Given this list of marker genes SLC6A4, GABRE, ERBB4, GRIN1, ELFN1, IGSF21, RAPSN, GRM1 (glutamate metabotropic receptor 1), ELFN2, LPAR1, CACNG2, GRID2IP, GPHN, DNAJA3, CHRNA6, NEO1, PRRT2, ATP2B2, ABHD6, STX1A, GRIK4, GRM7 (NCBI Gene Id 2917), EPHB2, LRFN1, ATP6AP2, CHRM3, GRIK2, CHRNA4, DLG3, KCTD12, TMUB1, CNIH2, GABRB3, SLC6A3, SSPN, MAGEE1, TMEM108, LRRC7, CHRM1, RYK, DAGLA, GABRG3, FARP1, P2RX1, GPR158, HTR3E, GRIA3, GRIN2D, KCNC4, LRRTM1, GRIN2C, GABRA1, ADORA2A, CHRNG, P2RY1, SIGMAR1, NLGN4X (NCBI Gene Id 64642), CHRNA10, CHRNA3, CACNG7, NLGN3, ACTN2, HCN1, HTR3C, LRRC4, MUSK, SHANK2, CLSTN2, CHRNA7, ADRA2A, ITGA8 (NCBI Gene Id 8516), LRFN2, FGF22, GABRA2, SORCS3, ANK3, CHRNB4, SEMA4C, CBLN1, HTR3D, ANP32E, CTNNB1, SLITRK1, GRIK3, CLMP, KCNJ4, KCNH1, GABRR2, ADAM22, TMEM240, LRFN4, SLC6A6, CNKSR2, LRRTM4, CLSTN1, GABRR3, CTNNA2, LRRTM2, GABRB1, CHRNB1, CACNG3, PCDH8, ADCY1, GRID1, LRRC4C, NLGN2, ASIC2, KCNMA1, GRIK5, ITGA3, SYAP1, SYNE1, MKLN1, SHISA9, TRPV1, FBXO2, HTR3A, C1QA, CACNA1C, EPHA7 (EPH receptor A7), PTPRO, GRIK1, CNTN2, SUSD4, DDN, ABHD17A, LRRC4B, CSMD2, RNF10, SYNDIG1, OPRK1, ATAD1, NETO1, FBXO45, KCTD16, FLRT3, NECTIN3, NAPEPLD, DCC, SRGAP2, CRKL (NCBI Gene Id 1399), GLRA3, VWC2, RPH3A, CNIH3, NLGN4Y, EFNB2, DLG4, CHRM2, GLRB (NCBI Gene Id 2743), IGSF9, GABBR2, LRRTM3, EPHA4 (NCBI Gene Id 401031), CACNG8, GRM5, GABRG2, ABHD17B, NSG2, LHFPL4, CLSTN3, TENM2, F2R, CHRNE, ADORA1, IQSEC3, PCDH10, PTPRS, CHRNB3, DMD, CHRNA9, IL1RAPL1, CHRM4, GRIA1, GRM3, AKAP9, CHRNA5, PDLIM4, SLITRK2, ANK1, DLG1, LIN7B, FLRT2, SHANK1, LRP8, KCNJ2, SYT1 (synaptotagmin 1), PTCH1, GABRR1, GABRA3, HTR5A, SHANK3, DLG2, GABRA5, PRR7, GABRB2, KCNC2, GPR179, GNB5, PICALM, GNAO1, SHISA6, FMR1, KCNC1, ANK2, ADGRL2, SHC4, DNM2, CNTN1, NRGN, LIN7A, NLGN1, SLITRK5, RAC1, GLRA1, KCNB1, ITGA5, KCNK2, NRP2, GRIA2, PCDH17, SLC16A7, PLXNB1, CRHR1, CHRM5, CNR2, NRP1, GRIN3B, VANGL2, GRIN3A, SEMA4B, COL13A1, ITGB3, KCNA2, GABRG1, DRD2, GRM2, DOK7, SEMA4F, SHISA7, CHRNA2, OPRD1, SHISA8, P2RX6, ADGRB3, GABRA4, SLITRK3, FXYD6, GABBR1, GRIN2A, NRCAM, AKAP5, GRID2, LRFN3, STRN, PLPPR4, CADPS2, DBN1, RGS7, KCND1, TAMALIN (trafficking regulator and scaffold protein tamalin), PRRT1, GLRA2, SLC9A5, KCND3, TACR1, KCNC3, RGS7BP, ARC, LIN7C (NCBI Gene Id 55327), C1QC (complement C1q C chain), SLC8A3, CHRNA1, ZC4H2, DAG1, GRIN2B, GABRA6, ABHD17C, CACNG4, SLC6A9, IGSF9B, RGS9, SEMA4D, NTRK3, FAIM2, KCTD8, TRAPPC4, DGKB, DRD1, KCND2, GRIP1 (glutamate receptor interacting protein 1), HTR2A, NETO2, HTR3B, SLC6A11, ASIC1, CSPG5, NOTCH1, PCDHB13, GSG1L, LRFN5, UTRN, CACNG5, GRIA4, ACP4, SLC12A5, DTNBP1, CDH10, GABRD, NSG1, CHRNB2, GABRQ, SORCS2, SLC30A1, PPP1R9B, CLCN2, SCRIB, CHRND, here is a description of the gene set: Human Gene Set: GOCC_POSTSYNAPTIC_MEMBRANE studied in species Homo sapiens A specialized area of membrane facing the presynaptic membrane on the tip of the nerve ending and separated from it by a minute cleft (the synaptic cleft). Neurotransmitters cross the synaptic cleft and transmit the signal to the postsynaptic membrane.